The following is a description of a gene set: species: Homo sapiens Negativism Opposing or not responding to instructions or external stimuli. Human Gene Set: HP_NEGATIVISM, and this is the list of marker genes: RTN4R, SYN2, DRD3, HTR2A, CHI3L1, APOL4, COMT, DAOA, APOL2, MTHFR